Given this list of marker genes Lmnb1 (lamin B1), Ednrb, Terb2, Pak1, Apeh (acylpeptide hydrolase), Ptger4, Phlpp1, Tmem38a (NCBI Gene Id 74166), Mtdh, Ranbp2, Pom121, Ints1, Cdh5, Ttc12, Bcl2l1, Nlrp6, Nutf2, Nup107, Surf4, Snca, Klk6, Lemd3, Clca2 (chloride channel accessory 2), Gapdhrt2, Atp5mf, Tent4a, Wtap, Nup93, Tbc1d20, Sumo1, Scrn1, Tmem120a, Nrm, Ghrhr, Ifi27l2a, Alox5, Lmna, Eno1b, Akap6, Nup85, Pak5, Sun3, Ptgds, Itprip, Nup133, Spata46, Kpnb1, Smad1, Ctnnb1, Phf11b, Nup50, Tor1aip1, Cep128, Stau2 (NCBI Gene Id 29819), Tor1a, Mindy3, Gata6, Hax1, Sun2, Cep131, Osbpl6, Nup58, Nup62, Rbm15, Itgb4, Zc3hc1, Aqp1, Fzr1, Dnajc2, Hsd11b1, Kash5, Gtpbp4, Tmem120b, Utp18, Kpna2, Gnaq, Nup153, Cenpv, Scai, Nup210, Terb1, Dtx2, Spin1, Ltc4s, Spag4, Nup54, Ipo5, Brap, Syne4, Smad3, Kpna4, Arl6ip6, Ccnd2, Rasa1, C9orf72, Rnf6, Cst3, Tmx4, Tex2, Gapdhrt, P2rx6, Phf11, Ak9, Qrich2, Brox (BRO1 domain and CAAX motif containing), Slc30a1, Cenpf, Tmc8, Ugt2b1, Nemp1, Ints2, Casc3, Gapdh, Taf3, Cept1, Phf11d, Mrgprf, Tor1b (torsin family 1, member B), Hacd3, Apc, Nlrp10, Lmnb2, Itpr3, Sigmar1, Rbmx2, Ambp, Dusp2, Sort1, Plpp6, Ankrd17, Prnp, Brip1, Pml, Dnajc1, Syne2, Mrps14, Rnf13, Tmpo, Cnep1r1, Prkg2, Zbtb1, Tmem109, Ei24, Tnks, Stx1a, Slc29a2, Mfsd10, Nat8f7, Noc4l, Gle1, Tm7sf2, Trappc2b, Senp1, Trim27, Repin1, Psen2, Lemd2, Ern1, Iigp1, Myorg, Nudt1, Nos1ap, Tmem43, Cpne1, Adra1b, Rnf123, Rrp12, Sdcbp, Zmpste24, Retsat, Ugt2b38, Rangap1, Nup42, Nav3, Atp1b4, Rb1cc1, Creb3l4, Plrg1, Phf20, Maco1, Nutf2-ps1, Disp3, Ahctf1, Prickle1, Tpr, Sult1e1, Syne3, Sun1, Ptger3, Tmem18, Cmtm3, Ugt2b37, Sh3bgrl2, Vapa, Erbin, Mx1, Tnrc18, Hoxa7, Ints5, Clmn, Iffo1, Il15ra, Psen1, Tmem97 (transmembrane protein 97), Pcm1, Emd, Bcl2l10, Slc22a3, Tmc6, Ptgs2, Ifi27, Rtel1, Itpr1, Zfp354c (NCBI Gene Id 319696), Nucb2, Tmem147, Dctn5, Pld6, Eno1, Osbpl8, Cdk4, Tmem201, Nemp2, Osbpl7, Grk5, Dmpk, Yeats4, Bcl2, Adra1a, Nup35, Ednra, Dnajb2, Phf11c, Gch1, Shisa5, Lpin1, Pum2, Akirin1, Txlng, Sephs1, Dync2i2, Ugt2b5, Tmem168, Ccnd1, Wdr3, Smox, Rif1, Klhdc2, Lrpprc, Anxa4, Lypla1, Sun5, Slc16a3, Kif5b, Mad2l1bp (MAD2L1 binding protein), Zfp383, Myo6, Egfr, Cuedc2, Smpd4, Cd38, Ndc1 (NCBI Gene Id 72787), Gsto1, Mx2, Nup205, Phf11a, Mlx, Dnajb14, Dhx37, Canx, Aaas, Thap7, Inpp4a, Gtf3c3, Unc50, Cemip, Fam169a, Kpna2rt, Aen, Hpn, Nsmf, Mrps23, Phf8, Ackr2, Tmem176b, Senp2, Dnajb12, Epc1, Gapdh-ps15, Osbpl3, Nat8f3, Ctdnep1, Myct1, Syne1, Tra2b (transformer 2 beta), Nup50l, Plcb1, Myof, Pafah1b1, Nup155, Fam209, Rap1gap2, Nudt9, Nup98, Prickle2, Dtl, Nr4a1, Gchfr, Lrrk2, Cptp, Cav2, Majin, Epha3, Tug1, Dhcr7, Nrxn1, Clic1, Tmem53, Bok, Xpo1, Lbr, Dpy19l2, Kcnh1, Alox5ap, Mpl, Nos1 (NCBI Gene Id 76730), Ebp, Mcm3ap, Habp4, Sirt1, Spast, here is a description of the gene set: Mouse Gene Set: GOCC_NUCLEAR_MEMBRANE Either of the lipid bilayers that surround the nucleus and form the nuclear envelope; excludes the intermembrane space. species: Mus musculus